The following is a description of a gene set: Enables the transfer of guanine nucleotides (GMP, GDP, and GTP) from one side of a membrane to the other. Mouse Gene Set: GOMF_GUANINE_NUCLEOTIDE_TRANSMEMBRANE_TRANSPORTER_ACTIVITY species: Mus musculus, and this is the list of marker genes: Slc46a2, Lrrc8a, Slc17a9, Slc19a1, Abcc4 (NCBI Gene Id 239273)